The following is a description of a gene set: The only cells of the hematopoietic system that undergo self-renewal for the lifetime of the organism are long-term hematopoietic stem cells and memory T and B cells. To determine whether there is a shared transcriptional program among these self-renewing populations, we first compared the gene-expression profiles of naïve, effector and memory CD8(+) T cells with those of long-term hematopoietic stem cells, short-term hematopoietic stem cells, and lineage-committed progenitors. Transcripts augmented in memory CD8(+) T cells relative to naïve and effector T cells were selectively enriched in long-term hematopoietic stem cells and were progressively lost in their short-term and lineage-committed counterparts. Furthermore, transcripts selectively decreased in memory CD8(+) T cells were selectively down-regulated in long-term hematopoietic stem cells and progressively increased with differentiation. To confirm that this pattern was a general property of immunologic memory, we turned to independently generated gene expression profiles of memory, naïve, germinal center, and plasma B cells. Once again, memory-enriched and -depleted transcripts were also appropriately augmented and diminished in long-term hematopoietic stem cells, and their expression correlated with progressive loss of self-renewal function. Thus, there appears to be a common signature of both up- and down-regulated transcripts shared between memory T cells, memory B cells, and long-term hematopoietic stem cells. This signature was not consistently enriched in neural or embryonic stem cell populations and, therefore, appears to be restricted to the hematopoeitic system. These observations provide evidence that the shared phenotype of self-renewal in the hematopoietic system is linked at the molecular level. Human Gene Set: GOLDRATH_NAIVE_VS_MEMORY_CD8_TCELL_UP Genes up-regulated in comparison of naive CD8 T cells versus memory CD8 T cells. from publication Luckey CJ, Bhattacharya D, Goldrath AW, Weissman IL, Benoist C, Mathis D (PMID 16492737) species: Homo sapiens, and this is the list of marker genes: SPTBN1, AMPD3, ST6GAL1, NFKBIZ, TUBB3, ZDHHC14, IFI27L2, MX1, MARK2, RBM38, KIF23, ISG15 (ISG15 ubiquitin like modifier), RNF19A, ILVBL (NCBI Gene Id 95885), RASGRP2, TBCEL, LDLR (NCBI Gene Id 3949), UBA2, TSC22D1, ITGAE, PLAUR, UBE4B, DAXX, MFHAS1, CD5, IDH2, TRIM25, RHOH, RFLNB, RMND5A, RAB3IP, NFIX, SLC12A7, ATP1A1, MRPS17, PRKCB, CBX6, IL6ST, TUBA1A, IRF7, SESN1, NOCT, MGST2, EZH2, STK10, ARHGAP39, CYTIP, EGR1, DDIT4, GSN, ACTN1, ADK, SNRK, PRKDC, RAMP1, SNHG6, TUBA1B (tubulin alpha 1b), ARID2, PSMA5, RSAD2, ADGRL1, IFIT1B, PBX2, ANAPC5, FASN, PRPS2, ENG, SFMBT2, RCAN3, MAP4K2, ILF3, PNPT1, CRY1, EZR, PTPRS, SRSF6, PIGA, IFT25, SEC11C, TNNT1, CCR9 (C-C motif chemokine receptor 9), MYB, SPRED2, CXXC5, RGCC, RBM4, UBE2D2, PDK3, EIF4G2, DNAJC1 (DnaJ heat shock protein family (Hsp40) member C1), LEF1, TSPAN13, CYB5A, EPHX1, INPP5B, MPP1, NDRG1, ZNRF1, ISG20, PPP2R5A, DAP, CACYBP, ST8SIA1, ADCY6, REV3L, RMND1, MATK, HIF1A, TALDO1, RAPGEF4, PPIC, TOP2A, MAP4K4, APEX1, TWSG1, RPS6KA2, DGKA, POLE2, CD8A, TMEM245, MRPL30, RPRD1A, RALGPS2, UCK2, RPL13A, CDKN2D, IRGM, ATP6V1D, NOTCH1, LGALS3BP, RPS25, TDRP, ST3GAL1, CCR7, TUBA1C, TCOF1, MARCKS, EHD1, PPDPF, NSMCE1, KLHDC2, PGD, UTP20, CDIP1, PHTF2, TTC3, GEMIN5, MAP7, FRMD6, PPA2, CNN3, HDAC2, ACVRL1, HDAC7, RPS8, ILRUN, GABRR2, PDK1, PRKD2, EXT1, SRM, GUCD1, HES6, MINPP1, GGT5, TSPAN32, PLAC8 (placenta associated 8), SMC4, ELOVL6, BZW2, CNGA1, TIMM9 (NCBI Gene Id 26520), ACTN2, PPRC1, NAB2 (NGFI-A binding protein 2), HLA-DOA, RGL2, GADD45A, DPH5, CCT5, SATB1, TMEM14C, NTPCR, DUSP2, DTYMK, TUBB, CCNL2, ACP5, DDX3Y, TMEM50B, ADPGK, TKT, TEC, PEPD, PDLIM4, STT3B, RGS10, INTS7, IKBKE, LTB